Given this list of marker genes HOXD13, PTHLH, MAP3K20, FIG4, VAC14, here is a description of the gene set: Human Gene Set: HP_APLASIA_HYPOPLASIA_OF_THE_DISTAL_PHALANX_OF_THE_HALLUX Aplasia/Hypoplasia of the distal phalanx of the hallux studied in species Homo sapiens